The following is a description of a gene set: studied in species Mus musculus Mouse Gene Set: MIR_100_3P Genes predicted to be targets of miRBase v22 microRNA mmu_miR_100_3p in miRDB v6.0 with MirTarget v4 prediction scores > 80 (high confidence targets). from publication Chen Y, Wang X (PMID 31504780), and this is the list of marker genes: Ndufaf4, Gm2042, Gria4, Eef1b2, Celf4, Stra6l, Abhd10, Fermt2, Arhgap19, Mettl21a, Pitx2, Speer3, Kpna6, Kmt2e, Phf3 (NCBI Gene Id 98560), Slco1a4, Nectin3, Trim2, Ube2n, Mtfmt, Gria2, Wdr26 (NCBI Gene Id 98607), Krt17, L1td1, Vps50, Col3a1, Ier5, Ncam2, Zfp711 (zinc finger protein 711), Itgb2l, Dll1, Srsf6, D430019H16Rik, Ski, Atad2b, Hipk3, Clip2, Nxpe2, Cyb5d2, Pcnx1 (pecanex 1), Cdh13, Plekha1, Crh (corticotropin releasing hormone), Osr1, Fam118b, Slc25a51, Vldlr, Magee1, Atpaf1, Yipf6, Hic2, Fry, Rnf112, Gm4894 (predicted gene 4894), 9930012K11Rik (NCBI Gene Id 268759), 4930486L24Rik, Abtb1, Hace1, Tra2a, Tent4b, Zfp518a, Zbtb16, Tent5a, Fem1c, Pou2f1, Pmepa1, Semp2l2a, Hspa2, Hoxa9